The following is a description of a gene set: Mouse Gene Set: GOCC_CUL5_RING_UBIQUITIN_LIGASE_COMPLEX A ubiquitin ligase complex in which a cullin from the Cul5 subfamily and a RING domain protein form the catalytic core; substrate specificity is conferred by an elongin-BC adaptor and a SOCS/BC box protein. species: Mus musculus, and this is the list of marker genes: Rnf7, Asb11, Arih2, Rbx1-ps, Elob, Rbx1, Asb9, Cul5, Asb4, Socs7, Ankrd9, Eloc, Spsb3, Pcmtd1, Socs2, Klhdc1, Rnf7l